Given this list of marker genes SLC25A19, OGDH (NCBI Gene Id 4967), SLC19A3, BCKDHA, BCKDK, SLC19A2 (NCBI Gene Id 7826), TKT, PDHA1, TPK1, here is a description of the gene set: Human Gene Set: WP_THIAMINE_METABOLIC_PATHWAYS Thiamine metabolic pathways studied in species Homo sapiens